Given this list of marker genes CDH5, CIPC, HNF4G, TGIF1 (NCBI Gene Id 91941), TNP2, LCA5L (lebercilin LCA5 like), HBZ, GJA4, CHRNA9, NHLH2, HIF1AN, SPATS2L (spermatogenesis associated serine rich 2 like), LRRTM4, ABCC1, ZBTB7A, KTN1, DOCK10, NIBAN2 (niban apoptosis regulator 2), ARHGAP31, EPOR, PARP4, PBX2, MRPL45, PUS10, TERB1 (NCBI Gene Id 283847), TERF1, CCDC63, CNNM2, USP16, B3GNT2, SON, SMAD3, FUCA2, ADAM22, SLC9A9, INO80, PLA2R1, GUCY1B1, MAB21L3, MERTK, ADGRV1 (adhesion G protein-coupled receptor V1), HIF1A, AXL, GPATCH8, DGCR6, MPC1, SCAF11, CCL7, TNFSF4, TRAT1, ZFP14, PELI1, EML1, CCDC120, SMNDC1, STK33, COMMD7, MTX2, S1PR4, ERO1A, SDCBP2, PDIA2, KIF11, ANKRD50, MAP4, MBNL2, CCN4, EBI3, MIOX, MED24, TFPI, GNG8, CDKN1B, ZNF524, ZNF471, LALBA, CD200, CCR7, DNMT3B, SLC49A4, ATP8B2, ATF3, NEB, BCOR, CARD19, CLN8, PPT1, ARMCX3, RAMP1, TAF11 (NCBI Gene Id 6882), ADGRF1, HYI, SRSF11, METTL9, MYO1F, AMPD2, CARD14, NIPAL3 (NCBI Gene Id 57185), SNRNP48, OPTN, ATP6V0A1, CYFIP2, RPL36A, ARC, KPNA7, SRP72, SCAF4, LRRC42, MXD3, RCOR3, MAPKAPK2, PPARG, RAB12, ADAMDEC1, THEM4, BMPER, RINT1, KMT2A, ARRB2, ZNF212, ITGA5, UTP3, ZCCHC9, PDGFB, GAP43, IL2, PATL1, GANAB, SP1, IPO8, REG3G, MSANTD2, SMN1, DDHD1, RAD52, POLK, GOSR1, TUT4, PDE1C, TNFAIP3, TARDBP, TMEM35A, SPINT1, HSPA4L, AQP7 (aquaporin 7), SPATA6, SOWAHA, TSC22D3, B2M, RAB40B, RASD1, CCDC66, CCDC85A, CFAP300, TRAF5, MED10, LY75, BVES, GALNT10, ICOSLG (inducible T cell costimulator ligand), SIT1, CDH17, XRN2, RPL27A, MPHOSPH6, HACD2, CCDC32, ALDH6A1, ZC3H7B, NDUFA12, TNFRSF14, MYC, SFR1, TMPO, SULT1B1, PDP1, ABHD16B, GABRP, PRCP, PAX3, SLC37A1, NARS1, SATB1, SIRT1, NEK4, PCDH10, AMMECR1, PXK, GNAL, RGS13, IL17A (interleukin 17A), ZNF655, IGSF9, CNDP1, TMEM263, ZC3H13, CD2AP, FAM118A, ATG9B, CTC1, here is a description of the gene set: Triggering of B cell receptors (BCR) induces a massive synthesis of NFATc1 in splenic B cells. By inactivating the Nfatc1 gene and re-expressing NFATc1 we show that NFATc1 levels are critical for the survival of splenic B cells upon BCR stimulation. NFATc1 ablation led to decreased BCR-induced Ca++ flux and proliferation of splenic B cells, increased apoptosis and suppressed germinal centre formation and immunoglobulin class switch by T cell-independent antigens. By controlling IL-10 synthesis in B cells, NFATc1 supported the proliferation and IL-2 synthesis of T cells in vitro and appeared to contribute to the mild clinical course of Experimental Autoimmune Encephalomyelitis in mice bearing NFATc1-/- B cells. These data indicate NFATc1 as a key factor controlling B cell function. from publication Bhattacharyya S, Deb J, Patra AK, Thuy Pham DA, Chen W, Vaeth M, Berberich-Siebelt F, Klein-Hessling S, Lamperti ED, Reifenberg K, Jellusova J, Schweizer A, Nitschke L, Leich E, Rosenwald A, Brunner C, Engelmann S, Bommhardt U, Avots A, Müller MR, Kondo E, Serfling E (PMID 21464221) Human Gene Set: GSE21063_3H_VS_16H_ANTI_IGM_STIM_BCELL_UP Genes up-regulated in B lymphocytes stimulated by anti-IgM: 3h versus 16h. species: Homo sapiens